Given this list of marker genes MAP1LC3B2, LAMP2 (NCBI Gene Id 3920), GORASP2, MAP1LC3C, MAP1LC3B, MAP1LC3A, here is a description of the gene set: Autophagosome and lysosome fusion, tethering factor, GRASP55. Pathway ID: N01722. Pathway type: Reference. Pathway class: nt06532 Autophagy. Pathway Definition from KEGG: LAMP2 == GORASP2 == LC3-II studied in species Homo sapiens Human Gene Set: KEGG_MEDICUS_REFERENCE_AUTOPHAGOSOME_AND_LYSOSOME_FUSION_TETHERING_FACTOR_GRASP55